The following is a description of a gene set: Genes up-regulated in bone marrow-derived macrophages treated with LPS for 4h: heterozygous versus homozygous knockout of MLL4. Histone methyltransferases catalyze site-specific deposition of methyl groups, enabling recruitment of transcriptional regulators. In mammals, trimethylation of lysine 4 in histone H3, a modification localized at the transcription start sites of active genes, is catalyzed by six enzymes (SET1a and SET1b, MLL1–MLL4) whose specific functions are largely unknown. By using a genomic approach, we found that in macrophages, MLL4 (also known as Wbp7) was required for the expression of Pigp, an essential component of the GPI-GlcNAc transferase, the enzyme catalyzing the first step of glycosylphosphatidylinositol (GPI) anchor synthesis. Impaired Pigp expression in Wbp7-/- macrophages abolished GPI anchor-dependent loading of proteins on the cell membrane. Consistently, loss of GPI-anchored CD14, the coreceptor for lipopolysaccharide (LPS) and other bacterial molecules, markedly attenuated LPS-triggered intracellular signals and gene expression changes. These data link a histone-modifying enzyme to a biosynthetic pathway and indicate a specialized biological role for Wbp7 in macrophage function and antimicrobial response. from publication Austenaa L, Barozzi I, Chronowska A, Termanini A, Ostuni R, Prosperini E, Stewart AF, Testa G, Natoli G (PMID 22483804) Human Gene Set: GSE30971_WBP7_HET_VS_KO_MACROPHAGE_4H_LPS_STIM_UP species: Homo sapiens, and this is the list of marker genes: PKM, PRKAG2-AS2, TIMM23, PPIF, FUT4, TMEM68, WNT5A, NF1, IRAK2, AMPD3, GPR68, DESI1, EBI3, SPRED2, ZNF697, SLC7A5, CXCL8, SLC1A3, TMEM138 (transmembrane protein 138), RAI14, PSMD14, TALDO1, PSMA5, SLC39A8, ITGB8, PLP2, NME1, TNFAIP6, CTPS1, LARP4, HIC1, NOP2, MSC, PHLDA2, AIFM2, SRXN1, TNS3, TMEFF1, PSMB5, BID, CXCL3, RCN1, AZIN1, CHUK, ELOVL7, NDP, DGKH, C15orf48 (NCBI Gene Id 84562), CD58, SLC43A3, HMGN2P46, SEM1, RABEPK, ODC1, SPATS2L, PSMC4, LRP8, POLR1A, MAPK13, PLEKHA3, LSM12, IDI2, WDR4 (NCBI Gene Id 55896), TXNDC9, SELENOS, MTF1, RRS1, LAMB3, N4BP1, PSMD7 (proteasome 26S subunit, non-ATPase 7), TRIM13 (tripartite motif containing 13), CXCL1, TNIP3, GSAP, FCER1G, G0S2, MZT1, TNFAIP3, PLAA, BMAL2, GFM1, MAMLD1 (NCBI Gene Id 653998), GLRX3, DNAJC10, PSMD1, LINC03025, TUBB4B, STX1A, TUBB (NCBI Gene Id 95295), GTF2E1, PSMA3, TUBB6, ZPR1, RAB5IF, FNDC3B, AK4, SNHG15, FPR2, UBE2V2, TNFRSF9, ZC3H12A, TREM1, FFAR2, AIMP2, ACVR1B, TMA16, DGAT2, ZNF473, TM9SF4, POGLUT3, C17orf58, CCT5, CDC37, SLC16A6 (NCBI Gene Id 9120), BTG3, PLAUR, MRPL47, BEND3, TPST1, TNIP2, CAVIN4, PLGRKT, MSC-AS1, ICAM1, ALDOA, PDLIM7, CLEC5A, CYP27B1, ASAP1, ADM, CXCL6, METTL1, ACSL5, EEF1AKMT3, FKBP4, JPT2, MET, PTX3, CMSS1 (NCBI Gene Id 84319), SLC7A1, NOP16, TUBB3, PACSIN2, SPHK1, DPP3, TXN, C1QBP, PTPN12 (protein tyrosine phosphatase non-receptor type 12), IL1B, MT1M, DISP1, NUDT9, SEC23B, KCNN4, SOD2, NETO2, AEN, SLC25A33, ALOX5AP (arachidonate 5-lipoxygenase activating protein), PPIL1, PDSS1, BBIP1, SH3PXD2B, GFM2, SERF1A (NCBI Gene Id 8293), TOMM34, CCL7, ZUP1, UCK2, GSR, RCN2, BTBD19, KANK1, HS3ST3B1, MAML2, NIT2, TMEM38B, MRPL15, PROCR (NCBI Gene Id 10544), OLIG2, RFX2, SLC7A11, CNIH4, TMEM45B, SP2-AS1, CD38, NIP7, POP1, ATP6V0A2, MFSD2A, UBE2Z, TRAF1, GEMIN4, ZBTB17 (NCBI Gene Id 7709), SLC41A2 (solute carrier family 41 member 2), PLK3 (NCBI Gene Id 1263), MSANTD3, PSMA6 (proteasome 20S subunit alpha 6, NCBI Gene Id 87553), CXCL5